Given this list of marker genes Sec61a2, Kpna3 (karyopherin subunit alpha 3), Lbr, Nup98, Pex13, Ipo4, Cabp1, Kdelr2, Cemip, Pom121, Ap2m1, Pex5l, Srp14, Ipo5, Kpna6, Tnpo2, Tomm40l, Tnpo1, Kdelr3, Tomm20, Srp54c, Ranbp6 (NCBI Gene Id 240614), Pex7, Tomm22 (translocase of outer mitochondrial membrane 22), Srp54a, Nup214, Pom121l2, Srp54b, Tomm70a, Brap, Kpna4, Srp68, Nup58, Nfkbia, Sec61a1, Timm22, Pex19 (NCBI Gene Id 19298), Kpna1, Tomm20l, Kpna2rt, Kpna7, Nup153, Kpna2, Pex5, Nolc1, Kdelr1, Kpnb1, here is a description of the gene set: species: Mus musculus Binding to a signal sequence, a specific peptide sequence found on protein precursors or mature proteins that dictates where the mature protein is localized. Mouse Gene Set: GOMF_SIGNAL_SEQUENCE_BINDING